Given this list of marker genes Akr1b1, here is a description of the gene set: This event has been computationally inferred from an event that has been demonstrated in another species.<p>The inference is based on the homology mapping from PANTHER. Briefly, reactions for which all involved PhysicalEntities (in input, output and catalyst) have a mapped orthologue/paralogue (for complexes at least 75% of components must have a mapping) are inferred to the other species. electronically inferred by orthology from the curated human pathway Reactome Pathway: Fructose biosynthesis studied in species Mus musculus part of: Fructose metabolism